Given this list of marker genes PLA2G4A, MAPK1, here is a description of the gene set: part of: Ca-dependent events Phospholipase A2 (PLA2) enzymes hydrolyze arachidonic acid (AA) from the sn-2 position of phospholipids. AA is a precursor of eicosanoids, lipid mediators involved in inflammtory responses. PLA2 enzymes function as regulators of phospholipid acyl turnover, either as housekeepers for membrane repair or for the production of imflammatory lipid mediators. There are diverse forms of PLA2 enyzmes including secretory (sPLA2), calcium-independent and cytosolic (cPLA2). The cPLA2 form which mediates arachidonic acid release is annotated here. Reactome Pathway: phospho-PLA2 pathway species: Homo sapiens